Given this list of marker genes Taok1, Arhgef2, Rdx, Frmd7, Map1a, Avil, Camsap1, Kank1, Mtpn (myotrophin), Dbn1, Fhod3, Tmod1, Mid1ip1, Kank3, Dyrk1a, Wdr47, Mid1, Kat2b, Tbcd, Atxn7, Tubb4a, Mapre1, Tmem67, Dlc1, Rbm14, Map3k1, Twf1, Tlr2 (toll-like receptor 2), Ssh3, Espn, Capg, Capza1b, Sptb, Capza3, Tacstd2, Cgnl1, Tmsb4x, Slit2, Trim37, Togaram2, Clasp1, Eml2, Vill, Specc1l, Nubp1, Phldb2, Shroom2, Snca, Dmtn, Smad4, Mfn2, Tmeff2, Add1, Gmfb, Myoc (myocilin), Capza2, Ccnf, S1pr1, Mkks, Evl, Kank2, Rp1, Pfn1, Ppfia1, Apc, Camsap3, Tpm1, Scin, Cracd, Tmod3, Stmn2, Arhgef18, Arpin, Wasf2, Diaph3, Pik3ca, Tpx2, Shank1, Hip1r, Ccdc88c, Was, Pfn2, Cav3, Vil1, Clip3, Arap1, Arhgap28, Add3, Bbof1 (NCBI Gene Id 72873), Ssh2, Camsap2, Ssh1 (NCBI Gene Id 384311), Lmod2 (leiomodin 2 (cardiac)), Ckap2, Tmsb15b2, Gas2l2, Iqschfp, Arfgef1, Arhgef7, Tmsb15l (NCBI Gene Id 399591), Sptan1, Ppp1r9a, Ttbk2, Svil, Spef1, Cdh5, Capza1, Eps8, Carmil1, Kank4, Sptbn1, Cyrib, Dnai3, Plekhh2, Bmerb1, Eml4, Pik3r1, Map6d1, Spta1, Trim54, Lima1, Clasp2, Katnb1, Coro1b, Gas2l1, Coro1a, Dbnl, Inpp5k (NCBI Gene Id 192772), Capn1, Lmod3 (NCBI Gene Id 320502), Carmil2, Inpp5j (NCBI Gene Id 170835), Map2, Lmod1, Apc2, Add2, Cib1, Arpc2, Cenatac, Prkcd, Rhpn2 (NCBI Gene Id 97401), Cdk5rap2, Flii, Pak2, Npm1, Hdac6, Myadm, Stmn1, Map1b, Tmod4, Fkbp4, Rhpn1, Sgk1, Shank3, Twf2, Tmod2, Prkn, Tjp1, Pecam1, Gmfg, Myh9, Kat2a, Fgf13, Mdm1, Pick1, F11r, Ctnna2, Gsn, Swap70, Hdgfl3, Capzb, Cfl1, Bbs4, Kifc1, Met, Arhgap6, Coro2b, Nav3, here is a description of the gene set: Any process that stops, prevents, or reduces the frequency, rate or extent of the formation, arrangement of constituent parts, or disassembly of cytoskeletal structures. Mouse Gene Set: GOBP_NEGATIVE_REGULATION_OF_CYTOSKELETON_ORGANIZATION species: Mus musculus